The following is a description of a gene set: from publication Chen Y, Wang X (PMID 31504780) Mouse Gene Set: MIR_1932 Genes predicted to be targets of miRBase v22 microRNA mmu_miR_1932 in miRDB v6.0 with MirTarget v4 prediction scores > 80 (high confidence targets). species: Mus musculus, and this is the list of marker genes: Corin, Usp33, Atf7, Slc32a1, Ankrd50, Fbxo4